Given this list of marker genes CLASP1, MYH11, ALS2, ARHGEF19, IL32, H2BC17, MYL12B, AMIGO2, VIM, NUP107, H3C11, DST, PPP2R5D, PPP1R12B, ROCK2, FAM169A, SGO1, DDRGK1, CYBA, CENPT, MCF2L, RNF20, GPS1, SWAP70, SKA2, PLEKHG4, PMF1, FMNL1, SENP1, PDE5A, LEMD3, RHOD, RCC2, MYH14, H2AC14, ARPC3, CHN1, H2AC19, ARPC2, ARHGEF12, DLC1, YKT6, MAPK1, VAMP3, TAGAP, PLEKHG6, NCF1, RALBP1, SCFD1, CDH1, ARHGAP11B, DVL1, ACTN1, KCTD3, CCP110, PIK3R4, SPTAN1, CCT6A, UACA, CCDC187, MEN1, STOM, WASF3 (WASP family member 3), GRB7, STX5, PPP1CB, SLC1A5, CDC42EP4, S100A9, NCOA2, ARHGAP19, CFL1, NUP43, PLD1, CDC42SE2, OBSCN, TMEM59, CCDC115, FGD5, SHMT2, ARHGAP24, CKAP4, TWF1, MAP3K11, MFN2, ARHGEF4 (Rho guanine nucleotide exchange factor 4), MACO1, FRS2, PLEKHG4B, ZNF512B, H4C1, SLC4A7, TOR1AIP1, OCRL, ARHGAP8, FAM135A, ARHGEF15, ARAP2, PLEKHG1, NCKAP1L, LRRC1, SGO2, FAM91A1, GIT1, EMC3, GMIP, ARHGEF18, SHKBP1, WIPF2, DOCK5, ARHGAP28, MSI2, ESYT1, ACTC1, NSL1, GOLGA3, H3C6, KLK2, TFRC (transferrin receptor), MYL9, PRC1, H4C13, WHAMM, PEAK1, H2AC4, NCKAP1, MYL6, BAIAP2, RBMX, STMN2 (stathmin 2), PLK1, STAM, RHOB, RAB9A, IQGAP3, NCF2, H2BC12, MYO6, DBT, ACTR3, ARHGAP9, CKB, PAK6, DIAPH1, PRKCZ, H2AC20 (NCBI Gene Id 8338), ANLN, DYNC1H1, MRTFA, ARAP1, VHL (von Hippel-Lindau tumor suppressor), PLD2 (NCBI Gene Id 5338), ARHGEF26 (NCBI Gene Id 26084), PCDH7, DYNC1LI1, CDC42, FRS3, MCAM, ALDH3A2, YWHAB, PKN2, TRAK1, ARHGEF39, RHPN2, SPTBN1, DOCK10, H3C7, MUC13, ARMCX3, FAM13B, H3C2, SH3PXD2A, STARD13, H4C15, RACGAP1, FAM13A, PRKCA, BAIAP2L2, STEAP3, PKP4, YWHAZ, BUB1B, CENPI, MYH9, ARHGEF25, TEX2, DIAPH2, PPP2R5B, KDM1A, UBXN11, ARHGAP25, YWHAG, VANGL2, NUP160, WWP2, ITGB1, WDR6, CENPA, NDC80, PPP2R5E, ITGB3BP, JUP, ARHGAP27, C1QBP, GRB2, GNA13, ZAP70, PRKCB, H4C6, FERMT2, FLNA, MTX1, YWHAQ, ARHGAP23, ARHGAP5, STARD8, WAS, RAP1GDS1, ARHGEF11, FGD3, RHPN1, ABI2, AKAP12, ARHGAP42, H3C14, VANGL1, ARFGAP2, ARHGAP30, ARHGDIA, PLXNA1, KIF18A, ANKLE2, NOXO1, TAX1BP3, ZW10, DSG2, ERCC6L, ARHGEF16, TRIP10, DYNLL1, RAC1, SRF, H2BC15, FMNL2, H2AC8, YWHAH, H3C12, ARHGEF10, TJP2, TUBB8B, SRGAP1, XPO1, DOCK9, LCK, ABL1, VRK2, TUBA1C, H2AC6, FLOT2, TIAM2, NCF4, LAMTOR1 (NCBI Gene Id 55004), TRAK2, FILIP1, ARHGAP33, ARHGAP26, BLTP3B (NCBI Gene Id 23074), RHOA, CENPH, FGD1, CENPQ, ARHGAP21, LIMK2, CDC37, ARFGAP3, GOPC, MYO19, CDC42BPB, H4C12, DSP, IQGAP2, KIF2B (kinesin family member 2B), FARP2, H2BC5, CENPS, SRGAP3, ARHGAP11A, SH3BP1, PLEKHG2, LIN7B, LBR, ARHGEF7, AURKB, TUBA1B, RHOT2, ARHGAP35, DOCK11, PIK3CA, CTTN, WIPF3, CTNNA1, NGEF, ZWILCH, ARHGEF17, H4C2, BIRC5, H4C14, MYO9B, RHOJ, DSG1, NDEL1, RAB7A, H2AJ, SPDL1, CDC42BPA, SLITRK5, DOCK6, ARHGAP12, TXNL1, CAV1, NOX3, PIK3C3, ARHGEF3, BASP1 (brain abundant membrane attached signal protein 1), DBN1, VAV1, PAK5, CSK, DYNLL2 (NCBI Gene Id 140735), H3C4, H3C10, TPM3, RHOF, ECT2, TMEM87A, PREX1 (NCBI Gene Id 57580), HSPE1, PLEKHG3, TAOK1, NUDC, SRRM1, CYBB, CCNE1, DLG5, MAPK11, DSN1, NDE1, NUP37, TUBB8, AR, EMD, GIT2, CENPO, RAC3, B9D2, SRGAP2, TUBB2A, FARP1, HSP90AB1, PPP2R1A, MTMR1, ARHGAP39, TMPO, NDUFA5, RHOBTB3, CLASP2, NF2 (NF2, moesin-ezrin-radixin like (MERLIN) tumor suppressor), ARHGAP18, H3-3B, MAPK3, RHOQ, SEH1L, ELMO2, SAMM50, ARAP3 (NCBI Gene Id 64411), CLTC, CPD, EFHD2, CENPE, MIS12, SYDE2 (NCBI Gene Id 84144), GJA1, FNBP1L, DVL3, MAPRE1, ARHGAP1, NET1, H2BC1, ARHGAP44, ROCK1, H2AC18, KNTC1, H4C11, MAPK14, KLK3, CDC42EP3, ADD3, H2AC7, MTR, GARRE1, S100A8, CENPN, H2BC12L, RND2, TUBB6, MAD2L1, RAC2, VCP, PPP1R12A, MOSPD2, STK10, WDR91, LRRC41, PTK2, RAB9B, COPS2, PIK3R2, AAAS, PAK2, BCR, KLC1, ARHGAP45, EPSTI1, JAG1, CYFIP2, NCKIPSD, DOCK1, FGD4, ARHGEF1, TUBB3, CDCA8, KDM4C, CDC42EP2, PLXND1, OSBPL11, DDX4, NCK1, CDC25C (NCBI Gene Id 995), AHCTF1, DEF6, VAV3, PLIN3, TUBB2B, ARHGEF28, CALM1, H2BC6, PAFAH1B1, CCT2, STBD1, CDC42EP5, TRA2B, LETM1, MFN1, CDC20, COPS4, ARHGDIB, POTEE, TIAM1, DDX39B (DExD-box helicase 39B), CAVIN1, MCF2, CENPK, PRKCD, ANKFY1, DLG4, ARHGAP29 (Rho GTPase activating protein 29), CFTR, HNRNPC, DOCK4 (dedicator of cytokinesis 4), MPP7, ACTB, FAM83B, ATP6AP1, RPS27, H3C1, ARPC4, USP9X (NCBI Gene Id 8239), ACTG1, BUB1, ABL2, DOCK2, OPHN1, KTN1 (NCBI Gene Id 8109), ITSN2 (NCBI Gene Id 6454), PLXNB1, DOCK3, KALRN, ARHGEF5, SOS2 (NCBI Gene Id 96829), CENPU, TUBB4B, CIT, PPP2R5C, ARHGEF9, SPC24, RHOT1, SCAI, ABR, H2BC10, SLITRK3, RASAL2, TMOD3, PRAG1, H2AB1, SKA1, TUBA3D, TUBA3E, ARHGEF40, KCTD13 (NCBI Gene Id 253980), RRAS2, CKAP5, CCDC88A, ARHGAP17, NISCH, TUBAL3, ACTR2, CTNNB1, WDR81, H2BC9, STAM2, TUBA3C, FMNL3, PKN3, NSFL1C, PAK3, CDC42EP1, KIF5B, ARPC1B, SNAP23, YWHAE, MAD1L1, H4C3, TAOK3, ARHGEF10L, DOCK8, CYFIP1, VAPB, CDKN1B, NUF2, IQGAP1, WASF2, HGS, NUP85, PAK1, ARL13B, SOS1, GOLGA8R, AKAP13, CPSF7, MYH10, SPEN, H2BC21, FLOT1, PDPK1, BRK1, PFN2, NOX1, CHN2, NCK2, PARD6A, SOWAHC, SPATA13, H2BC8, LMNB1, DYNC1I1, PICALM, SPC25, H2AX, DAAM1, STK38, ZWINT, PREX2, DYNC1I2, CEP97, RANBP2, DEPDC1B, RHOV, PIK3R3, H3C8, CAPZB, H2AZ2, CENPF, HTR7, TRIO, RND1, GFOD1, CPNE8, BAIAP2L1, SCRIB, H2BC11, RHOH, RHOU, ARHGAP20, ARHGAP10, H4C5, CCT7, KLC4, ARHGAP40, CUL3, PLEKHG5, ABCD3, BTK, NDUFS3, ERBIN, HINT2, RTKN, KNL1, MYLK, KIDINS220, ANKRD26, PGRMC2, RND3, ARHGAP4, FNBP1, ROPN1, KIF2A, BUB3, TUBA8, DOCK7, WASL, H4C8, RALGAPA1, WDR11, TUBA4B, ARHGAP15, PHIP, CENPL, TUBB1, H2BC4, PTK2B (NCBI Gene Id 5748), PPP2R5A, WASF1, EPHA2, DYNC1LI2, RASGRF2, H2BC7, LMAN1, DVL2 (dishevelled segment polarity protein 2), ARHGEF6, ARHGAP6, INCENP, MYO9A, CLIP1, H3C3, SFN, RAPGEF1, RHOBTB2, VAV2, SYDE1, PPP2CA, H2BC26, RANGAP1, ARHGAP32, ACBD5, ARHGAP31, NHS, H2BC13, HMOX2, EVL, NOXA1, RBBP6, ARHGDIG (Rho GDP dissociation inhibitor gamma), KIF14, KLC2, PAK4, NIPSNAP2, FGD2, PPP1CC, TPM4, ARPC5, H2BC14, SH3RF1, PIK3R1, RHOBTB1, LIMK1, H4C9, SEMA4F (NCBI Gene Id 9408), ABI1, TUBB4A, BCAP31, DNMBP, WIPF1, SLK, PFN1, TUBA4A, RHOG, DIAPH3, H4C4, H4C16, SEC13, FAF2, PPP1R14A, PKN1, KIF5A, H3C13, ARPC1A, HSP90AA1, TUBA1A, STIP1, CENPC, CENPP, H2BC3, ARHGAP22, TNFAIP1, KIF2C, CENPM, ITSN1, PPP2CB (protein phosphatase 2 catalytic subunit beta), PIN1 (peptidylprolyl cis/trans isomerase, NIMA-interacting 1), PPP2R1B, ARHGEF2, H3-3A, SRC, H3C15 (H3 clustered histone 15), PTPN13, RHOC, NUP98, PARD6B, NUP133, KLC3, here is a description of the gene set: species: Homo sapiens Human Gene Set: REACTOME_SIGNALING_BY_RHO_GTPASES_MIRO_GTPASES_AND_RHOBTB3 Signaling by Rho GTPases, Miro GTPases and RHOBTB3